Given this list of marker genes CADM1, CLU (clusterin, NCBI Gene Id 1191), IGFBP2, SFRP4, HAPLN1, SGK1, TNC, ITGA6, here is a description of the gene set: species: Homo sapiens Aberrant transactivation of a certain set of target genes by the beta-catenin and T-cell factor/lymphoid enhancer factor (TCF/LEF) transcription factor complexes has been implicated in the process of intestinal epithelial cells entering early colorectal carcinogenesis. A rat intestinal epithelial cell line IEC6 became elongated, extended protrusions at cell periphery, and increased stress fibers and focal contacts upon the induction of beta-catenin protein stabilized by deletion of the N-terminal glycogen synthase kinase-3beta (GSKbeta) phosphorylation sites (beta-catenin DeltaN89). We used the GeneChiptrade mark oligonucleotide microarray system to examine approximately genes and identified genes whose expression was altered during the course of this morphological transformation. Those genes included known negative regulators of the Wnt signaling pathway, Sfrp4 and Axin2; extracellular matrix and related molecule, Hxb and Crtl1; cell adhesion and cytoskeletal proteins, Podxl, Igaf4, and Itab6; and molecules involved in the insulin and insulin-like growth factor (IGF) signaling pathways, Enpp1, Igfbp2, and Sgk. We report the finding that insulin-like growth factor-binding protein-2 (IGFBP2) is a direct target gene of the beta-catenin and TCF/LEF complexes. The IGFBP2 protein interacts with integrins. Disruption of the multigene network system regulating cell adhesion and cytoskeleton may be crucial in the initiation of colorectal carcinogenesis. Human Gene Set: NAISHIRO_CTNNB1_TARGETS_WITH_LEF1_MOTIF from publication Naishiro Y, Yamada T, Idogawa M, Honda K, Takada M, Kondo T, Imai K, Hirohashi S (PMID 15735679) Genes regulated by CTNNB1 and whose promoters contain binding sites for LEF1.